The following is a description of a gene set: from publication Amit I, Garber M, Chevrier N, Leite AP, Donner Y, Eisenhaure T, Guttman M, Grenier JK, Li W, Zuk O, Schubert LA, Birditt B, Shay T, Goren A, Zhang X, Smith Z, Deering R, McDonald RC, Cabili M, Bernstein BE, Rinn JL, Meissner A, Root DE, Hacohen N, Regev A (PMID 19729616) mouse primary BMDCs were stimulated with tlr ligands and gene expression changes were profiled on Affymetrix arrays studied in species Homo sapiens Genes down-regulated in comparison of control dendritic cells (DC) at 1 h versus those stimulated with CpG DNA (TLR9 agonist) at 1 h. Human Gene Set: GSE17721_CTRL_VS_CPG_1H_BMDC_DN, and this is the list of marker genes: AGXT, PEX5L, ROS1, FGF7, KIFC3, CLRN3, SEMA3F, FAM81A, SF3B1, DNAJA2, PTAFR, MRNIP, POU2F1, SFXN4, ZC3H3, TMEM119, GCNT1, KIF13A, CSNK1E, FNDC4, PCBD1, MYCN, CYP2B6, RBM7, CCDC167, KCNJ4, NUDCD1, GCNT3, MTTP, SGMS1, DYNLT3, BDNF, TENT2, CLIP1, KRT84, FBXO31, CHORDC1, OMP, SEMA3C, CCDC71L, ARFGAP2, LLGL2, DTNB, IER3, ROBO1, MAP3K8, ANXA10, HS6ST3, DNAJB4, TNFSF11, RARG, MYMK, PCDH18, ZFP30, KRT1, ARF6, ENAM, PHLDB1, SPRYD7 (SPRY domain containing 7), CYTH1, MTMR1, KRT17, NENF, FBLN7, ZMIZ1, AGT, SPA17, CKMT2, SLC6A1, GPR3, XPA, IER5 (immediate early response 5), ADRB2, MZF1, ART3, TOP1, SOWAHC, NDN, PIP, SAMSN1, ITIH4, TCTE1, CXCL10, TRA2B, LIN9, CCNL1, PDGFRA, ERBB4, ZPBP, EBI3, CBX4, DMTN, BRWD1, PRELP, TSC22D1, PPBP, APOM, MARCHF7, IFT57, UBL4B, ZSCAN5B, TBK1, PCDHAC1, HSPA8, INPP1, SCML2, FRS3, GTF3C1, SLC32A1, IL21 (NCBI Gene Id 59067), CDKN1A, EGFL6, HYAL2, IL1RN, LGI4, MTHFD2, LIMA1, APOA5, RGS20, PDHA2, USP25, EMSY, FGF5, KCNJ12, SLC6A2, DSCAML1, GTF2B, AKIP1, ACKR2, CCRL2, SLC25A25, INTS6, CLEC4F, DBH, SERPINA3, FAM131B, DALRD3, GJA1, ARID5B, KIN, ETV3, PSCA, TTC28, TSPAN15, NTSR2, LIG3, SERPINB9, RAB4A, SHISA2, HLF (NCBI Gene Id 3131), REM2, CHD1, KCMF1, CD14 (NCBI Gene Id 929), MDM2, MPP4, RANBP10 (RAN binding protein 10), KL, SLK, ZFPM2, NKX6-1, FAS, ADGRA3, LZTFL1, MACROD2, DNAJB2, HOXC6, ENTPD4, GIPC2, ENPP5, PLK2, SNRNP70, CCN1 (NCBI Gene Id 3491), DSCAM, IER2, RIPK4, PRSS41, HHATL, RAB27B, IFT81, OAF, GINM1, HCN2, ZSCAN22, FTL, CHIC2, NEFH, CARD14, CNOT2, SPTBN4, CNTN2, SIX1, ADRA1B, SECTM1, GJB3, WNT9B, TTC39C, HAAO (3-hydroxyanthranilate 3,4-dioxygenase), MIA, ALOX12